Given this list of marker genes EIF4G2, SCNM1, ACSL5, TCERG1L, PROX1, SLC17A6, CYB561D1, ENTPD7, DYRK3 (dual specificity tyrosine phosphorylation regulated kinase 3), MPZ, RCOR2, TIAL1 (NCBI Gene Id 8430), NSL1, IL20, CEP350, DCLRE1B, DCHS1, SCAMP3, NECTIN4, BSND, SFXN2, PAK1, NAV2, ELF5, PRRX1, TCEANC2, MOV10, CLCNKA, ARMH3, RRM1, SPOCK2, NDC1, UBE2D1, OR10A5, WNT9A, BMI1, DLG2, CNTF, SH2D4B, SYT13, RALGPS2 (NCBI Gene Id 55103), CASZ1, TMEM9, RET, SDHC, GNG3, MYOF, TMSB4XP1, PTPRJ, ADAM12, SMYD2, EPHA2, KCNK18, HSD11B1, TRMT1L, IRAG1, TLL2, KBTBD4, PRUNE1, LRRTM3, ADD3, RASAL2, ELOVL1, MINDY1, PCNX2 (NCBI Gene Id 9845), PGAP2, FGF19, MFN2, RIMKLA, CACNB2, MMP21, RPA2, SOX6, GLUD1, SMG7, ZC3H11A, UBE4B, ELAVL4, TSG101 (tumor susceptibility 101), NHLH2, STX5, RGL1, OVOL1, CNR2, ZNF488, DPYD, GADD45A, UBAP2L, SERPINC1, CREM, ZBTB18, EIF4EBP2, LHX4, ADGRB2 (NCBI Gene Id 576), GOLPH3L, FGGY, PDPN, NPPA (NCBI Gene Id 90230), SLC26A9, TSPAN2, SORCS1, COL11A1, AMPD3, FRA10AC1, ANK3, GRK5, SEMA4G, CYP2E1, S100A3, DPH5, SYTL1, LMO1, ADGRL2, MPPED2, EDEM3, CRYBG2, DHCR24, RNF11, PCGF5, AP5B1, NEXN, MFSD14A, DGAT2, ARID1A, COL13A1, LCOR, NCDN, ZBTB41, TDRD10, SKIDA1, TRIM33, PDC, PRDM2, SORBS1, CGN, TIMM10, NDUFS3, TARS2, TMEM51-AS1, FBXW4, NDUFC2, IQGAP3, UCP2, AHNAK, RAB30, TACSTD2, UAP1, NEUROG3, GAB2, SGIP1, TMEM51, PTCH2, SCUBE2, CDK1, BSCL2, KRT8P41, RERE, PHTF1, LEMD1, PLA2G4A, ESRRG, DKK1, NARS2, MIR9-1HG, CUBN, IL19, KLHDC8A, GRK2, LIN28A, CD160, PTPN7, ARNT, MYCL, GFRA1, GBF1, CFHR5 (complement factor H related 5), SLC25A28, EFNA4 (NCBI Gene Id 1945), TMEM59, SWT1, KLHDC7A, PHF21A, HNRNPR, VAX1, LYSMD1, NEK7, CAP1, RCN1, ARL3, SLC16A9, TCF7L2, MTFR1L, ATXN7L2, SLC43A3, A1CF, AHCYL1, CD247, KCNQ1DN, SIPA1, LRMDA, SLC6A9, PANK1, HMCN1 (NCBI Gene Id 83872), LRP8, CTNND1, UBE2U, INA, DUSP10, NAV1, RUNX3, THAP12, CEPT1, WNT8B, AAMDC, RABGAP1L, ACTR1A, RSF1, HABP2, SV2A, ASB13, BARHL2, YARS1, ZFYVE9 (NCBI Gene Id 9372), NIPAL3, DDR2, FAM110D, RNF19B, TSKU, SLC22A8, PAX6, AP4B1, here is a description of the gene set: Genes having at least one occurrence of the motif TCAAAG in the regions spanning 4 kb centered on their transcription starting sites. This matches the LEF1, TCF1 transcription factor binding site V$LEF1_Q2 (v7.4 TRANSFAC). studied in species Homo sapiens Human Gene Set: LEF1_Q2